Given this list of marker genes CIITA, RFX5, B2M, RFXANK (regulatory factor X associated ankyrin containing protein), RFXAP, here is a description of the gene set: A deviation from the normal concentration of beta-2-microglobulin in the blood. species: Homo sapiens Abnormality of circulating beta-2-microglobulin level Human Gene Set: HP_ABNORMALITY_OF_CIRCULATING_BETA_2_MICROGLOBULIN_LEVEL